The following is a description of a gene set: studied in species Mus musculus Mouse Gene Set: GOMF_VOLTAGE_GATED_MONOATOMIC_ANION_CHANNEL_ACTIVITY Enables the transmembrane transfer of an anion by a voltage-gated channel. An anion is a negatively charged ion. A voltage-gated channel is a channel whose open state is dependent on the voltage across the membrane in which it is embedded., and this is the list of marker genes: Clcnkb, Vdac1, Ano6, Clcn6, Tmc4, Vdac2, Clcn1, Slc17a3, Gpr89, Clcn2, Clcn3, Clcn4 (chloride channel, voltage-sensitive 4), Clcn5, Clcnka, Vdac3, Ano1